The following is a description of a gene set: Human Gene Set: GOBP_REGULATION_OF_CD4_POSITIVE_CD25_POSITIVE_ALPHA_BETA_REGULATORY_T_CELL_DIFFERENTIATION Any process that modulates the frequency, rate or extent of differentiation of CD4-positive, CD25-positive, alpha-beta regulatory T cells. species: Homo sapiens, and this is the list of marker genes: LGALS9, HLA-DRB1, KLHL25, HLA-DRA, IFNG, IL2RG, FOXP3, KCNK18